The following is a description of a gene set: Any process that activates or increases the frequency, rate or extent of feeding behavior. Human Gene Set: GOBP_POSITIVE_REGULATION_OF_FEEDING_BEHAVIOR species: Homo sapiens, and this is the list of marker genes: AGRP, OPRK1, GHRL, CFAP20, MC1R (NCBI Gene Id 4157), NPY, RXFP4, GHSR, SGIP1, NR4A3, INSL5